Given this list of marker genes ZNF385A, INTS12, MTR, ADNP, PRNT, DNAJC25-GNG10, FRA10AC1, OTUD7B, UMPS (uridine monophosphate synthetase), CISD2, B4GAT1, FBXO21, CNKSR3, VPS51, HTR5A, ANXA2R, ZKSCAN8, VGLL4, HJURP, TUBG2, SLC25A30-AS1, VTI1A, CXCL8, PIK3R1, MIR4510, MFSD6, PDCD6P1 (NCBI Gene Id 728613), RBMS3, PRRG1, METTL23 (methyltransferase 23, arginine), WDR36, DOC2A, ARID1B, INTS14, UQCC2, FOSL2 (FOS like 2, AP-1 transcription factor subunit), FGGY-DT, MIR22HG, ARID2, QRFPR, TMEM177 (transmembrane protein 177), TMEM198, SMG8, HEXIM1, RPA2, ENSG00000268129, NAA16, CCDC180, TTLL12, ASXL1, SRP72, DMAC2L, RAI14, INTS6L, TSC22D1, MIR361, VPS13B, WDR11-DT, PJVK, NR4A2, CTH, VEZT, SCAMP4, TTI2, ACTG1P25, RN7SL824P, RESF1 (retroelement silencing factor 1), LGALS1, SLC17A7, ATP8B1, CLASP1, CIRBP, LINC02987, EGR3, TVP23C-CDRT4, LINC01569, CCNT1 (NCBI Gene Id 904), BTG1, MIR1976, ZNF579, CBLL1-AS1, MTUS1, GFRA3, TP53BP2, FCGR2A, CARTPT, DEPTOR-AS1, PBX1, B3GNT6, TEDC1, THAP10, ZNRD2, HNRNPH2, TMEM79, USPL1, SLC16A10, TESC, TPRG1, FSD2, NSUN7, ZNF35, SRSF11, CADPS, HS1BP3, KIF23-AS1, R3HCC1, LINC00665, TRIM14, BMS1P4-AGAP5, RFC3, ALG10, KDM1A, MIR4799, PTGES3L, LINC01775, NCAM1, FBXO27, ZSCAN26, METTL15, PNP, CRYM, DMKN, ZNRD2-DT, BTBD6, ETS2, COPG1, TAC1, ZFAND1, ZNF225-AS1, SNX24, MT-TN, TAGAP-AS1, ODF2L, ELF2P3, COQ3, DDIT4, ZC3H12C, PARK7, IGFLR1, IRF6, HNRNPD-DT, LINC00431, PARP12, LRIG3, TGIF1, HBS1L, MRPL21, LRRTM3 (NCBI Gene Id 347731), ANXA2, ANKRD19P, SYCP2L, SERTAD3-AS1, THSD4, DHX16, ENSG00000249236, GTSF1, LINC02558, CCKAR, CAGE1, SPAG9, LINC01730, OMA1, ENC1, CFAP90, RNU4ATAC, PAAF1, MPLKIP, GATA6, TMT1A (thiol methyltransferase 1A), HYKK, EZR, DDX5, KRR1, USP53, SMG5, PHGDH, PHLDA1, JMJD6, C1orf159, CHD1, TPM1, ZNF470-DT, ACTB, GAS7 (NCBI Gene Id 8522), SLC14A2, CCDC141, LINC01145, NLRC5, SASH1, RGMB, WDR11, CBLL1, TDP2, CHMP4A, ETV4, SCNM1, GARIN2, ZNF544, SLC27A5, POGLUT1, ENSG00000228044, RAF1, NBEA, UBA52, IMMP2L, LRP3, ZNF688, GLUD1P3, PCOLCE, CRAT, PKD2, MAP1LC3B, ECSIT, ZBTB20, ANKRD7, CRHR1, IFIT1, ZNF264, ANO8, NME1, SCN2A, UBA2, AP5M1, ARSI, SUGCT, ABHD12, TBL1XR1, JOSD1, CD302, GRPEL2, PDZRN4, HDAC5, IPO4, ATP6V0A1, UBE2L6, PTP4A2, DNAJC12, LINC01897, FLJ16779, TEFM, TAF1A-AS1, ARL5AP3, CRELD1, ENSG00000228021, CNIH3, ATPAF1, SFRP4 (secreted frizzled related protein 4), SEMA3A, TRABD, HTR3A, GSTCD, CPEB4, HSPA4L, MET, IFT56, VPS13A, COA8, EMG1, CAPS2 (NCBI Gene Id 84698), SASS6, PARP2, DUSP26, TMX2, RTTN, ERBB3, PRR3P1, OGFRL1, TVP23C, NDUFS7, ZNF416, NUS1P1, ZNF652-AS1, ZNF566, RN7SL346P, LINC01337, SSBP2, DARS2, MYL6, LGALS8, CERCAM, PFKFB3, RIMOC1, EIF2D, ITGB3BP, FAM24B, SNW1, GJA1, RCOR3, MIR9-3HG, LAMTOR2, JPX, CCDC192, TBX18, GLB1L, LINC01010, TRMO, FPGT, SEC14L1, ARPC3, TIMM9, TRMT1, SLCO4A1-AS2, RNU6-433P (RNA, U6 small nuclear 433, pseudogene, NCBI Gene Id 106481315), MED8, NADK2, ST8SIA1, FASTKD5, DDX54, CCDC121, ADD3, RASGRP3, ARPC4, YIF1A, RPL30P11, CDC42P2, STK16, RAB30, TMEM101, TCHP, ELMOD3, LOXL1-AS1, MT-TC, ZNF646P1, RPL10, IFI44L, ZFP28, LINC02366, MT-TY, RPS6KA1, LINC02893 (NCBI Gene Id 440173), BRK1, NOSIP, MED26, RPS15AP6, RETSAT, ZNF283, PRMT5, NOXRED1 (NADP dependent oxidoreductase domain containing 1), UAP1, ADAP2, KRT80, CIMIP6, BCDIN3D-AS1, BRWD1, TATDN3, PIGK, MCCC1, NEDD4L (NCBI Gene Id 93998), SEC16B, PEX3, NKAIN4, PRPF19-DT, TBC1D19, USP44 (ubiquitin specific peptidase 44), KIF5B (kinesin family member 5B), NSL1, NEK9, SRP14, CATSPERD, TRDMT1, USP32, PDE4B, EFCAB7, MAN2C1, AHNAK, BAG5, NGDN, STEAP1B-AS1, STUM, BRAP, RNF220, LIG1 (NCBI Gene Id 3978), SEMA6A, PRORP, GALNT12, KIF1C, SLC2A11, SNX25, LMAN2 (lectin, mannose binding 2), RPS14, EXOC5, SIRT4, C9orf72, SREBF1, LYPD5, ZNF383, OASL, MGAT5B (alpha-1,6-mannosylglycoprotein 6-beta-N-acetylglucosaminyltransferase B), MAST4, CHD1L, EXOSC3, PHIP, SMAD2, CDK5RAP1, MED23, EIF2B3, TRMT5, COPS4, PUS10, PPIG, CDIPTOSP, ZNF221, TBXA2R, RPL23AP8, RPL27, LRRC71, ZNF131, EFL1, TSKU, ADK, STING1, STOX1, SPAG1, IGLV3-1 (immunoglobulin lambda variable 3-1), IDS, RPS12P23, IMPDH2, ZNF329, H3-3B, CDK5, MYL12A, SYTL2, WDR62, LTBP1, SIAH1, MIR8073, FCHO2-DT, SSH2, LINC01091, ZNF891, KLHL7-DT, NSUN4, N6AMT1, MS4A8, SAMD4B, SCAMP3, MAST3, CEP350, TEX38, HACD1, ZNF585B, PRKAG2, PKMP3, ZNF501, NSMCE2 (NCBI Gene Id 286053), SYNRG, TLE6, FZD7, NME1-NME2, GIHCG, FBXL19, DNAJB12, LINC02895, AP2A1, PRKRA, CASP9, TRUB2, PCK1, CACNA1E, PSMD3 (proteasome 26S subunit, non-ATPase 3), CEP85L, CARNMT1-AS1 (CARNMT1 antisense RNA 1), HNRNPD, ACBD5, PHLDA1-DT, RARB, LINC02709, GPR141, FBXO3, SPRYD7, B9D2, KPNB1-DT, CLK1, STK35, INTS5, NEAT1, HMGB1 (NCBI Gene Id 3146), CMTR1, HSP90AB1, KLHL7, C19orf12, GUK1, ZNF232-AS1, LIPA, MT-TA, GOLGA3, VAMP1, HSDL2, EEF1D, TTC23, LYRM7, INPP4B, PTGES3L-AARSD1 (NCBI Gene Id 100885850), TMEM167B, RGS5, ZNF548, PPP1R12A (NCBI Gene Id 4659), ITIH4, GLA, G2E3, SNRNP27, TRIM4, ZNF784, MED18, TMEM126B, PHF12, TRAPPC2, ENSG00000232995, NUBPL-DT (NUBPL divergent transcript), ACOT13, OSTM1, AP3S2, ZNF518A, RABGAP1L, ACLY, FCHO2, BASP1-AS1, CPNE8, CREM, NKAPP1, ZFP82, SLC24A1, SRP14-DT, ABI2, KRTAP5-14P, LRIF1, NLGN1, TM7SF3, ZNF597 (zinc finger protein 597), USP48, NDE1, ZNF10, BCL9, PDE4C, PAFAH2, DISP1, AK5, CECR2, UBE2T, SKP2, GSTK1, DSTYK, ZNF569, LMNTD1, DLGAP1-AS1, ARPC4-TTLL3, CDIP1, ARHGAP17, TGFBR2, GOLM2, PXMP4, ENSG00000232876, SIX2, FBXW7, MIR9-1HG, TDO2, PPM1D, RGMB-AS1, SLC43A1, NRAS, DTWD2, KAT7, ETFDH, ZBED9-AS1, ZMYM1, ZNF25, POLB, DNAJA3, IFT122 (intraflagellar transport 122), MIR1284, UACA, CCT6B, ESM1, ZNF398, ENAH, TMEM132A, SLC39A3, FGD6, KIAA0586, THAP1, ZNF414, CABP1, MRPS23, MARVELD3, DDX20 (DEAD-box helicase 20), VPS13B-DT, IMPDH1P9, LINC01460 (long intergenic non-protein coding RNA 1460), DENND10P1, KCNK1, GREM2, RNF38, GORASP1, ACTN1, RAD9B, ZNF790, LINC02960, NUBPL, INCA1, RAB4A, NR2F1, SHROOM3, ZNF780A, TADA3 (NCBI Gene Id 10474, transcriptional adaptor 3), ZNF775, HRCT1, JADE2, GPR84-AS1, GPR85, ZNF224, FAM13A, RN7SL521P, ADD2, BRD4, MCTP2, ZDHHC6, MYO1D, RELT, RFX5-AS1, IRGQ, NAA60 (NCBI Gene Id 79903), TLK2, PITX1, GP6-AS1, PTPA, TIPIN, U2SURP, DRAM2, IMPDH1 (inosine monophosphate dehydrogenase 1), EHD1, CHPF, SPAG4 (NCBI Gene Id 6676), RCAN1, BCAS2, DRG2, NUP155, ADGRV1, SLC25A44, AKT2, NAE1, BBC3, AOC1, ZNF706, OXSR1, PYROXD1, PANK1, METTL6, ZNF391, TADA2A, PTGES3, SLC16A14, BROX, NUF2, ARMC5, ZNF181, TOMM40L, PTRHD1, LIN54 (lin-54 DREAM MuvB core complex component), CD68, RBM34, RNU5F-8P, MAPKAPK5-AS1, TRMT13, STKLD1, CHRM3, METTL3, ALDH4A1, RXYLT1, KANK1, ARMH3, ENSG00000269954, MRPL24, SLC14A1, PORCN, EXO5-DT (EXO5 divergent transcript), LMBRD2, SEC22B, FAM174A, TESC-AS1, DHRS13, MTCO3P12, MARVELD2, SAMD5, ENSG00000251095, SELENOP, UBOX5, SNORD104 (small nucleolar RNA, C/D box 104), MED21, VPS25, EIF2S3, DCTPP1, LINC02608, ZMPSTE24, CFAP206, EPC1-AS2, C18orf21P1, NPHS1, HSPA9, ZNF345, EWSAT1, EPDR1, YWHAQ, MTFR1, TMEM91, APOL2, ZNF48, NIP7, VWA8-AS1, TDRD10, MRPS31, LRIG3-DT, SH3RF2, ARHGAP15, SRSF4, DAB1, SGK1, KLHDC9, LINC01508, OTUD7A, NFIA-AS1, CD24, CACTIN-AS1, HDAC4-AS1, ANKRD13C, STRN3, SLC4A2, ZNF527, VWA8 (NCBI Gene Id 23078), INTS6L-AS1, RN7SL617P, PEX13, RAP1B, PRDM6, ZNF8 (zinc finger protein 8), PDE11A, SLC36A1, ABCA7, STMND1, NBPF1, HDAC4 (NCBI Gene Id 9759), ABHD18, CCDC162P, SHARPIN, FMO5, BRF1, ZFP57, NSMCE4A, GNG4, KPNB1, ZNF66, GLS2, RPL39L, SC5D, PSG5, TAB1, GNG12-AS1, STX18-AS1, CFL1P4, TNFAIP8L2, PLCXD2, SAFB2, ZNF521, ZNF587B, LINC02598, GRN, CENPL, CDIPT, DNAJC1, TRIB1, FAM98B (NCBI Gene Id 283742), RFX5, MTLN, HS3ST3A1 (heparan sulfate-glucosamine 3-sulfotransferase 3A1), ZNF443, TBX6, PDE4D, SF3A3, TSPAN9, KDM6B, TAF2, LONP1, NDST4, NOL3, C9orf40, TUBA1A, KRTDAP, MAPKAPK5 (NCBI Gene Id 8550), PARP9, FAM174A-DT, CCDC134, MTND5P11, EPB41L4A, ADAMTS1, BIRC3, PLD3, MIPOL1, KIAA1586, COA4, TK2, RNU4-60P, NEUROD4, STX18 (NCBI Gene Id 53407), S1PR1, SNX14, MOB4, ISOC1, LINC02614, ZNF689, SLC7A7, NPAS3, TBPL1, IPP, GPATCH3, RPL35AP36, ITSN1, SRP72P2 (NCBI Gene Id 414748), LOH12CR2, MBTPS2, SRRM5, ARHGEF12, MAPK4, MBD4, PKN3, PSMA6, TIFA, DENND2B, CHEK2, SNORA50C, TOP3B, TMEM170B, EML2, BACH2, NUDT15, LINC00662, MAFG, ENSG00000221345, ODAD4, DOCK7-DT, STC2, PANX3, MICALL1, ADGRB1, SLC11A2, KIFC3, VKORC1, RNU4-71P, DDR1, RAD52, LINC01852, ZNF576, MPV17L2, RANBP3L, ENO2, MFSD8, NEMF, SUPT5H, FKTN-AS1, TRAF4, GABARAPL1, CLIP1, SNHG25, STXBP3, SCG2, WARS2-AS1, XPO6, PRPF19, ALG10B, MVB12A, TRAPPC9, KLHDC8A, LAMA4, FAM76A, ENSG00000254251, GAD2, C19orf47, ZNF425, RASAL2, ZMPSTE24-DT, ZNF566-AS1, SLC35F3, PMP22, SLC38A6, NBPF15, COQ8B, PIGL, FADS1, PAFAH1B3, GNB2, TMCO1, AURKAIP1, HNRNPU (NCBI Gene Id 3192), FRMD4A (FERM domain containing 4A), FRMD6, H2AZ2-DT (NCBI Gene Id 105375261), TEX9, RNU5F-1, DNAJC16, CYP4F3, OSBPL7, FAM117A, ZNF570, HMGA2, GSTA4 (glutathione S-transferase alpha 4), CAMK4, TTLL7, NDUFAF1, MON1A, CACTIN, CFAP410, PWP1, PFKFB3-AS1, GSTO1, DCTN1, ECE2, C10orf88B, ZNF487, COX16, VAX1, POU2F2, NCAPG2, RPL7, GLRX2, RNU7-96P, NOXA1, ANKRD26, BSDC1, ECHDC3, GATA6-AS1, SNHG20 (NCBI Gene Id 654434), LINC00896, CHD9, MIR4674, DLG2, CT62, CABLES1, LINC01586, UBXN7, MFAP3L, JMJD1C, RUFY3, NSA2, RCAN2, RBBP5, BMS1, RITA1, LRRC49 (leucine rich repeat containing 49), TUT1, ZNF140, ENSG00000265445, RNF145, ZCCHC4, FBXL20, CCDC107, ALOX12B, TFAP2A, CGRRF1, STRC, LINC01182, LINC01556, UBL7-DT, SERTAD3, THAP7-AS1, CLIC4 (chloride intracellular channel 4), PKHD1, C10orf95-AS1, PPP6R1, MIR575, SEC13, BNIP1, MAF1, PIP4K2C, RMDN1, MLLT3, ZSCAN31, RBMS3-AS3, PTPN9, TTC21A, NR0B2, PDK4-AS1, ZFP28-DT, SCOC, S100A4, SPECC1L, MIR1302-3, TMED7 (transmembrane p24 trafficking protein 7), PCSK1, CNPY1, ARHGAP28-AS1, MAP2K5, ZC3HC1, TMEM116, FAM169A-AS1, ZNF470, FBXL14, ZNF529, UBE2D1, ATG12, LINC01159, TMC3-AS1, MILIP, DOCK7, B4GAT1-DT, THADA, SMARCD2, UGT8, TAP2, UBQLN4, TXNRD2, PRELID3BP5, SYNGR4, ABR (ABR activator of RhoGEF and GTPase), RERE, HEATR5A, TRAFD1, SCAND3, RNU11, RPS15AP39, TSKU-AS1, AP3B1, EPHA7, TRIM39, CNPY3, ERAS (NCBI Gene Id 3266), APLP1, AGPAT4, THOC5, PDK1, RN7SL3, LOXL1, YIPF5, LSM5, CIT, ENTREP1, GAB1, ING3, AKTIP, OSGIN1, PCSK5, GTPBP3, GNAL, KIF23, ZSWIM7 (zinc finger SWIM-type containing 7), FNBP4, PDPN, MRPL44, CH25H, FAXDC2, SNORD13, AHCYP7, SPRY2, ZNF232, PIK3C2B, HEATR5A-DT, CABP1-DT, ZNF225, FOXJ3, SPOCD1, IGHMBP2, COG8, DDX41, SLCO2A1, NOTCH1, PRSS27, PRKAB1, MSL2, HNRNPL, SYNE1, ZNF567, PGD, ADAT3, LINC00910, PRICKLE2, RNU6-554P, GBA1, FAM174B, PGAM1P5, MADD, PORCN-DT, EZH1, PDIK1L, SRP54, IL1RAP, USP1, POLR3A, HMGB2, ENDOD1, BHLHE40-AS1, TRIM15, EPB41L1, LINC02136, ENPP3, PHACTR3, LRRC40, LINC01322, PHB2, ZNF354B, LRRC37A17P, EPHX1, NSG2, TIGD1, UBL7, RPP25L, FGFR1, MIR762HG, PPP1R42, GSX1, SCP2, ARHGAP32, NKX2-1, CCNC (cyclin C), TMED1, ALKBH7, EIF5A2, HCG18, FBXO31, EXOSC6, RPL37, C12orf42, PIPOX, BMPR1B, GOLGA8A, ENKD1, ARIH1, LTA4H, SMG6, C6orf47-AS1, PTPRD, REPIN1, EAF1, ZNF8-ERVK3-1, REPS1, ZNF540, HSPB6, DAGLB, MAP3K7, ATG4C (autophagy related 4C cysteine peptidase), PRDM1, IGF2BP3, C12orf76, ZNF567-DT, PITX3, SUCO, ANKRD40, TMBIM4, STARD5, C17orf75, EMC4, ATF7IP, PGAP2, CYP20A1, SLC30A10, TVP23B, GSS, ZNF875, PPP1R16A, PPOX (protoporphyrinogen oxidase), ZNF599, COQ4, UBAP2, KDM2A, HMGCS2, SEPTIN9, LRRIQ3, PCDHGB2, RDH10, B4GALNT1 (NCBI Gene Id 550623), CFAP61, RSPH3, CANX (NCBI Gene Id 821), CCNA2, ARHGEF2, ARB2A, COPS7B, ATP6AP2, ATXN7L1 (ataxin 7 like 1), CACNA1A, NDUFB7, TARS2, RPS13P4, LINC01359, HSD17B4, FPGT-TNNI3K (FPGT-TNNI3K readthrough), ADAT2, SHKBP1, UQCC1, TBX3, RHOT1, EYA4, USP30, GFM2, APOA1-AS, GFI1 (growth factor independent 1 transcriptional repressor), RNF217, GPR6, LINC01122, GPX8, ATP10D, ALG3, HLTF, MIR5087, SMARCC2, SPECC1L-ADORA2A, C1orf53, PROSER3, HMGN3P1, SEC23B, ZNF25-DT, RAB30-DT, DNAJC9-AS1, ZIC2, RPSA, LGALS8-AS1, ARHGAP28, ZNF155, ZNF616, RPL7AP60, CALM2, EXO5 (NCBI Gene Id 64789), TTC19, CDC14A, GOLM2P1, SNORA80D, ZFP30, RPL3, ITGA3, THAP7, TAF1A, MIR4519, SYCE1L, TM2D2, BCORL1, GUSBP18, SNRPD1, NDST1, ENSG00000247416, TSG101, SART3, MTF2, MTOR, TOB2, TAFA2, WFDC21P, RDH12, EIF4E2, DMAP1, HMGB3P22, EXD3, SYT9, PPP2R3C, RN7SKP114, ARID1A, CAB39L, MBP, TUBA5P, CLMP, BORCS5, ANKRD13C-DT, DST, STK10, ZNF121, CDC37L1, KRBA1, TSC22D2, WASF3, CHST8, DDB2, ZMYM3, RNF186-AS1, UBE4B, TXNDC15, GPN1, INO80C, ENSG00000215156, TPD52L1, UBE2D3, BRD1, ZNF808, ABHD2, KANSL3, SLC36A4, LINC03060, DNAJC25, CDK12, ADRA1A, BCAN-AS2, MIR4521, ACAD10, VPS29, BMS1P4, TINF2, TCF4, FGFBP3, TIMM22, RPS10P29, DERL1, LONRF3, COMMD2, LRRC17, RPL23AP85, CAMTA1, DHRS9, PDE1B, LMBR1, ZNF223, NRXN3, LCORL, SEH1L, MLEC, TAX1BP1-AS1, TMED7-TICAM2, here is a description of the gene set: species: Homo sapiens Human Gene Set: ZNF549_TARGET_GENES from publication Yevshin I, Sharipov R, Kolmykov S, Kondrakhin Y, Kolpakov F (PMID 30445619) Genes containing one or more binding sites for (ZNF549) in their promoter regions (TSS -1000,+100 bp) as identified by GTRD version 20.06 ChIP-seq harmonization.